Given this list of marker genes CREB5, HSD3B1, AGT, CALML5, ATF4, ATF6B, CTSG, ATF2, CAMK2B, PLCB2, CALM3, CYP11A1, CREB3L4, AGTR1, CREB3L2, CAMK4, HSD3B2, CAMK2A, ITPR1, CMA1, CALM2, CAMK2D, CALML4, CALM1, CAMK1G, AGTR2, ITPR2, CYP11B2, CAMK2G, CREB3L1, CALML3, CAMK1 (NCBI Gene Id 8536), ATF1, CREB3, CALML6, ACE, CAMK1D, GNAQ, CREB1, REN, CREB3L3, CYP21A2, ITPR3, STAR, here is a description of the gene set: studied in species Homo sapiens Human Gene Set: WP_RENINANGIOTENSINALDOSTERONE_SYSTEM_RAAS Renin-angiotensin-aldosterone system (RAAS)